The following is a description of a gene set: species: Homo sapiens Human Gene Set: GOBP_REGULATION_OF_ARP2_3_COMPLEX_MEDIATED_ACTIN_NUCLEATION Any process that modulates the frequency, rate or extent of actin nucleation mediated by the Arp2/3 complex and interacting proteins., and this is the list of marker genes: WASHC2A, DNAI3, CORO1B, AP1AR, BRK1, WASH6P, NCKAP1, CTNNA2, ABI2, ARF1, WASHC4, CARMIL1, ARFIP2, CARMIL2 (NCBI Gene Id 146206), CARMIL3 (NCBI Gene Id 90668), GMFB, PICK1, WASHC3, FCHSD2, WASHC1, WASHC2C, ARFIP1, GMFG, WASF3, WASHC5, WASH3P, WASF2, RNH1, CYFIP1, HIP1R (NCBI Gene Id 9026), WASF1